Given this list of marker genes BARD1, ABRAXAS1, RBBP8, RPA1, DNA2, RPA4, RAD50, UIMC1, WRN, MRE11, BABAM1, BRCC3, NBN, RPA3, BRCA1, BLM, BABAM2, RPA2, here is a description of the gene set: DNA end resection and RPA loading. Pathway ID: N01446. Pathway type: Reference. Pathway class: nt06506 Double-strand break repair. species: Homo sapiens Pathway Definition from KEGG: MRN == CtIP == BRCA1+BARD1 == UIMC1+ABRAXAS+BABAM1+BRE+BRCC3 -> BLM,WRN+DNA2+MRN == RPA Human Gene Set: KEGG_MEDICUS_REFERENCE_DNA_END_RESECTION_AND_RPA_LOADING